Given this list of marker genes COLCA1, VANGL1, PHOX2A, HGS, GLRX3 (glutaredoxin 3), ABCB10, REEP1, KITLG, PRODH2, WNT10B, FGFR2 (fibroblast growth factor receptor 2), GLMN, TIRAP, GRID2, PYM1, REEP4, THOC3, SLC7A3, CXCL17 (NCBI Gene Id 284340), FDFT1, IRGM, EIF3C, SUCLG1, ERH, DRD2, KERA, TMEM121, PCGF5, SCN2B, EIF4EBP1 (eukaryotic translation initiation factor 4E binding protein 1), GRHPR, CCNK, GZMA, KRTAP12-2, CHRNA2, POMGNT2, UGT8, C1orf105, MICAL2, RBPJ, GJB5, CPB1 (NCBI Gene Id 1360), FLT3, GPI, KCTD1, HCN3, TSPO2, HOXB7, CENPN, FES, E2F1, NAP1L1, PLAC1, RABL2A, RPA2, WNT16, SHROOM4, NICN1, SLC9A5, SPDYE18 (NCBI Gene Id 102725128), PDSS2, LCE2B, ALDH1L2, SEMA7A, ANGPTL4, PLA2G12A, GRK1, RRBP1 (ribosome binding protein 1), NOVA2, MARK1, CLCN1, PTGFRN, CMSS1, MPP2, PKIG, CYP26A1 (NCBI Gene Id 1592), SDF2L1, PAOX, SLC28A3, DOK7, PFKM, PCBD1, NPY5R, SLC35A4, SH3GL2 (SH3 domain containing GRB2 like 2, endophilin A1), USP13, CBLC, SRXN1, AGPAT3, WNT8B, UBE2T (NCBI Gene Id 29089), CTF1 (cardiotrophin 1), SOWAHB, CRTAC1 (NCBI Gene Id 55118), MBL2, SEMA3B, HIC1, TMEM144, SYCE2, SCRN3, NR1I2, FZD2, GAD1 (NCBI Gene Id 50977), CKB, NPTX1, TNFRSF13C, GPR173, PMVK, MMS22L, EPHB1, SH3PXD2B, BAAT, OTOF, POLA1, WBP11, TFF2, RAB36 (NCBI Gene Id 9609), DENND5B, TUBA8, SEMA3F, PRIMA1, NEO1, SPEG, WDR12, POLDIP2, SHH, CSMD2, PLCD4, MPV17L, SKA3, ZDBF2 (NCBI Gene Id 57683), MBOAT7, RPH3A, MTFR2, HOGA1, FFAR2, SYT1, TFG, BEND4, SMC1B, TRIM10, BCL2L10, KANK2, SCEL, SOX21, CLTA, BTNL2, SLC37A4, GINS4, NUP62, DUSP22, RNASEH2B, PML, HPRT1, IRX1, RRM1 (ribonucleotide reductase catalytic subunit M1), SIRT3, SOAT2, CCHCR1, PPP1R13L, NUP133, ZG16, CBLN1, DCUN1D5, GNAO1, CAV1, INSRR, MINDY3, NF1, OR10AD1, CELF3, BBS5, EVC2, ITGB3, TUBB6, WNT7A, ATF7, FOXH1, PTGFR, MAD1L1, MAP3K9, MS4A3, FBXL7, NECAB3, TM9SF4, RNF182, GSDMC, SYTL3, BCAN, SUV39H1, SHISA9, INSC, ATP5PB, ACOX2, MAP9, TKT, CHAC1, MTUS2, ALPG, HES5, here is a description of the gene set: Genes down-regulated in comparison of regulatory T cell (Treg) versus effector T cells. from publication Yu A, Zhu L, Altman NH, Malek TR (PMID 19185518) Interleukin-2 receptor (IL-2R) signaling is essential for T regulatory (Treg) cell development and homeostasis. Here we show that expression of IL-2Rbeta chains that lack tyrosine residues important for the association of the adaptor Shc and the transcription factor STAT5 in IL-2Rbeta-deficient mice resulted in production of a normal proportion of natural Treg cells that suppressed severe autoimmunity related with deficiency in IL-2 or IL-2R. These mutant IL-2Rbeta chains supported suboptimal and transient STAT5 activation that upregulate the transcription factor Foxp3 to normal amounts in natural, but not induced, Treg cells. Using cells T cell obtained from normal C57BL/6 mice and mice harboring Treg cells with impaired IL-2R signaling, gene expression profiling revealed many targets in peripheral natural Treg cells that were IL-2-dependent and a substantial overlap between the Treg cell IL-2-dependent gene program and the Treg cell transcriptional signature. Collectively, these findings demonstrate that a critical, and perhaps minor, subset of IL-2-dependent targets in Treg cells is indexed to a low IL-2R signaling threshold and that a substantial proportion of the Treg cell gene program is regulated by IL-2. CD4 T effector cells also showed many IL-2R-dependent gene and these also overlapped in a distintive manner with the IL-2-dependent genes of Treg cells and the Treg gene signature. species: Homo sapiens Human Gene Set: GSE14350_TREG_VS_TEFF_DN